The following is a description of a gene set: Mouse Gene Set: MIR_7087_3P Genes predicted to be targets of miRBase v22 microRNA mmu_miR_7087_3p in miRDB v6.0 with MirTarget v4 prediction scores > 80 (high confidence targets). from publication Chen Y, Wang X (PMID 31504780) species: Mus musculus, and this is the list of marker genes: Prkcz, Epha8, Pmm2, Zfp148, Pde3a, Snx30, Cdk13, Acsl4, Prpf4b, Copz1, Rapgef1, Rassf2, Ptpn12, Grm1, Pxn, Tbc1d10c, Trim60, Stim2, Pacsin1, Fam193a, Efr3b, Kcnk3, Rnf24, R3hdm1, Ago2, Carmil1, Sf3b2, Ptprt, Agpat3, Ano6, Ano1, Cmc1, Ddx4, Arcn1, Marf1, Slc30a7, Mobp, Arhgap6, Tbc1d8b, Adam12, Ttyh3, Selenon, 4930563E22Rik, Tmem250, Ccdc78, Nfat5, Rab40b, Stam2, Col24a1, D630045J12Rik, Hipk1, Kctd4, Ccdc86 (NCBI Gene Id 74079), Rap1a, Hibadh, Gpd1l, Zmynd19, Mmp12, Rnf114, Ihh, Tmem109, Zfp300, Kazn, H6pd, Mapk6, Htt, Leng8, She, Lta4h, Atf7, Nkd1, Edc3, Fbxo41, Irs4, Bcorl1, Smad3, Carm1, Crtc3, Tnfsf18, Git1, Phf21a, Cenpu, Gimap3, Zfp276 (NCBI Gene Id 57247), Robo1, Fat3, Gtf3c5, Tfap2a, Fbxo45, Slc25a36, Mpig6b, Igsf9b, Cldn23, Stk4, Csgalnact1 (NCBI Gene Id 234356), Sstr4, Mindy3, Hectd1, Trappc9, Limk2, A530016L24Rik, Acy1, Cdk6, Natd1, Nek9, Katnb1, Cep170b, Etnk2, Tfdp2, Abr, Nod1